The following is a description of a gene set: studied in species Homo sapiens Human Gene Set: LAKE_ADULT_KIDNEY_C3_PROXIMAL_TUBULE_EPITHELIAL_CELLS_S1_S2 from publication Lake BB, Chen S, Hoshi M, Plongthongkum N, Salamon D, Knoten A, Vijayan A, Venkatesh R, Kim EH, Gao D, Gaut J, Zhang K, Jain S (PMID 31249312), and this is the list of marker genes: FRMD4B, CNTN4, WWOX, PDE8A, SLC4A4, DPYS, RBM6, SLC16A9, FRMD3, VPS13A, IGF1R, PLEKHA5 (pleckstrin homology domain containing A5), OGA, SAMD5, FGD4, CWF19L2, RORA, VWA8, CDK14, MBD5, CGNL1, LRP2, ANKIB1 (NCBI Gene Id 54467), KCNQ1OT1, MAST4, SORCS1, MIR100HG, SLC17A1, PPFIBP1, SDK1, PLEKHA6, PCDH15, ZBTB38, NFIA, FTX, PDE7A, ZNF804B, SPAG9, ANK2, FHIT, SCAPER, PCCA, LINC01515, SNHG14, RERE, PTH1R (parathyroid hormone 1 receptor), MME, CRYL1 (NCBI Gene Id 51084), AFDN, PPARA, ANKRD11, BHMT, EBNA1BP2, SIPA1L1, DYNC2I1, TTC28, BCAS3, CNKSR3, PTPRG, FKBP5, DPH6, AKAP13, AGXT2, LINC01060, ACSM2A, GALNT18, PUM3, ZC3H13, SLC13A3, TNRC6B, THOC2, RNF152, GPHN, ALDOB, COMMD10, SIK2, PCLO, CUBN, TLN2, NEDD4L, SLC2A9, FRAS1, SRRM2, TINAG, TRPS1, ANKS1B, NFIB, SLC1A1, ARHGEF28, AFM, DENND1A, GMDS-DT, RALYL, INSR, TACC1, SORBS2, SLIT2, CSPP1, EXOC4, SCMH1, ZBTB16, ZBTB20 (zinc finger and BTB domain containing 20), FARP1, PRRC2C, N4BP2L2, SUMF1, PLXDC2 (plexin domain containing 2), LINC01320, LPP, MYO6, TRPM3, EPB41L3, FHOD3, GOLGB1, PBX1 (PBX homeobox 1), SRSF11, ERRFI1, AOPEP, TNRC6A, TFDP2, LINC00871, ABLIM1, BNC2, GRAMD1B, GOLGA4, SLC13A1, SLC28A1, BCL2, LRMDA, CPM, RHOBTB1, AIG1, SLC17A3, PLG, MACROD2, LUC7L3, KCNJ15, CHD9, EHBP1, ASH1L, GPX3, SLC5A12, RMST, CCDC198, NRP1, NEAT1, ANK3, MSRA, PRUNE2, L3MBTL4, PPP1R21, NHS, ENOSF1, SNX29, PKHD1, ADAMTS9-AS1, PCSK5, SLC16A12, PATJ, TRABD2B, PAX8, KANK1, SETBP1, UBE2E2, SMYD3, TEAD1, GPC6, PDE4D, RAB11FIP3, DLG2, FGGY, KANSL1L (KAT8 regulatory NSL complex subunit 1 like), NCKAP5, P3H2, COL4A1, CLDN10, PNISR, NOX4, HIBCH, ENPEP, WDR72, MAP3K13, RERG, CALD1, ASTN2, CRADD, SYNE2, TNS1 (tensin 1), PTPRM, AGAP1, CUX1, RBM47, RHEX, NLGN1 (NCBI Gene Id 22871), HPN, ACMSD, SAFB2, RBM25, ANKRD26, PLEKHA7, UGT2B7, WDFY3, ULK4, GALNT14, GLYAT, PTPRJ, SREK1, PDZD2, PARD3, ACSM2B, PTH2R, SUGCT, DIP2C, ARHGAP6, ZHX3, PRKN, SMIM2-AS1, MAPK10 (NCBI Gene Id 5602), PTPRD, DANT2, RABGAP1L (RAB GTPase activating protein 1 like)